The following is a description of a gene set: Human Gene Set: HP_ABNORMAL_BLOOD_GAS_LEVEL Abnormal blood gas level species: Homo sapiens An abnormality of the partial pressure of oxygen or carbon dioxide in the arterial blood., and this is the list of marker genes: CD40LG, RHD, MARS1, MYL2, RYR1, CNOT1, TPM3, PTRH2, MUC5B, ITGA7 (integrin subunit alpha 7), TERC, ACTA1, NKX2-1, TERT (NCBI Gene Id 7015), PARN, STN1, SLC35A1, EIF2AK4, TPM2, RTEL1, ABCA3, SMPD1, PHOX2B, RHAG, HACD1 (3-hydroxyacyl-CoA dehydratase 1), SFTPC, RHCE, SFTPA2, MAP3K20, FAM13A, SELENON, LONP1, ZFPM2, DPP9, CSF2RB, AHDC1, ENG (endoglin), NDUFS8, SFTPA1, CSF2RA, CACNA1S, DSP, BTNL2 (NCBI Gene Id 56244), HLA-DRB1, FBN1, SFTPB, SOX9, FGFR3, STAC3, GATA6, SLC34A2, MYH7 (myosin heavy chain 7), HBB, ATP11A, LRP12 (NCBI Gene Id 80002)